Given this list of marker genes Cdon, Csnk1a1, Arrb2, Gas8, Ihh, Kif3a, Ptch1, Grk2, Shh, Gas1, Arrb1, Dhh, Smo, here is a description of the gene set: Mouse Gene Set: REACTOME_ACTIVATION_OF_SMO Activation of SMO studied in species Mus musculus